Given this list of marker genes Dcstamp, Tyrobp (NCBI Gene Id 22177), Trem2, Ocstamp, Adam9, Stat1, here is a description of the gene set: Any process that modulates the frequency, rate or extent of macrophage fusion. species: Mus musculus Mouse Gene Set: GOBP_REGULATION_OF_MACROPHAGE_FUSION